The following is a description of a gene set: High CD99 expression levels and rearrangements of the EWS gene with ETS transcription factor genes characterize the Ewing's sarcoma family of tumors (ESFT). CD99 is a cell surface glycoprotein whose engagement has been implicated in cell proliferation as well as upregulation and transport of several transmembrane proteins in hematopoietic cells. In ESFT, antibody ligation of CD99 induces fast homotypic cell aggregation and cell death although its functional role in these processes remains largely unknown. Here, using an RNAi approach, we studied for the first time the consequences of modulated CD99 expression in six different ESFT cell lines, representing the most frequent variant forms of EWS gene rearrangement. CD99 suppression resulted in growth inhibition and reduced migration of ESFT cells. Among genes whose expression changes in response to CD99 modulation, the potassium-channel modulatory factor KCMF1 was consistently upregulated. In a series of 22 primary ESFT, KCMF1 expression levels inversely correlated with CD99 abundancy. Cells forced to express ectopic KCMF1 showed a similar reduction in migratory ability as CD99 silenced ESFT cells. Our results suggest that in ESFT, high CD99 expression levels contribute to the malignant properties of ESFT by promoting growth and migration of tumor cells and identify KCMF1 as a potential metastasis suppressor gene downregulated by high constitutive CD99 expression in ESFT. from publication Kreppel M, Aryee DN, Schaefer KL, Amann G, Kofler R, Poremba C, Kovar H (PMID 16314831) species: Homo sapiens Genes down-regulated in ESFT cells (Ewing's sarcoma family of tumors) after knockdown of CD99 by RNAi. Human Gene Set: KREPPEL_CD99_TARGETS_DN, and this is the list of marker genes: KMT2A, BCL2L2, INSIG1, KIF21B, RABGAP1L, EBF1, HIPK3